Given this list of marker genes IL17B, HSD11B2, HSD11B1, CYP3A4, IL17F, IL17C, LBP, CYP27A1, ACOT6, GPR183, CYP8B1, ACOT1, SULT2A1, ACOT4, INSIG1, SULT2B1, HSD3B7, IL17D, SLC27A5, DHCR7, CYP46A1, AKR1C4, EPHX2, NR1I2, ACOT9 (NCBI Gene Id 23597), CYP39A1, SCP2, AMACR, EBP, BAAT, ACOT8, AKR1D1, ESR1, CYP7B1, ACOT12, ACOT13, ACOT11, RORC, CYP7A1, THEM5, ACOX2, DBP, SLC27A2, IL25, ESR2, CH25H, ACOT7, ACOT2 (acyl-CoA thioesterase 2), UGT3A1, IL17A, NR1H2, here is a description of the gene set: Human Gene Set: WP_OXYSTEROLS_DERIVED_FROM_CHOLESTEROL studied in species Homo sapiens Oxysterols derived from cholesterol